The following is a description of a gene set: studied in species Mus musculus from publication Cui A, Huang T, Li S, Ma A, Pérez JL, Sander C, Keskin DB, Wu CJ, Fraenkel E, Hacohen N (PMID 38057668) Mouse Gene Set: CUI_T_CELL_GD_RANKL_RESPONSE_UP Genes positively differentially expressed in cell type: γδ T cell upon treatment with cytokine: RANKL in mouse lymph nodes in vivo. Cytokines mediate cell-cell communication in the immune system and represent important therapeutic targets. A myriad of studies have highlighted their central role in immune function, yet we lack a global view of the cellular responses of each immune cell type to each cytokine. To address this gap, the authors created the Immune Dictionary, a compendium of single-cell transcriptomic profiles of more than 17 immune cell types in response to each of 86 cytokines (>1,400 cytokine-cell type combinations) in mouse lymph nodes in vivo. A cytokine-centric view of the dictionary revealed that most cytokines induce highly cell-type-specific responses. For example, the inflammatory cytokine interleukin-1β induces distinct gene programmes in almost every cell type. A cell-type-centric view of the dictionary identified more than 66 cytokine-driven cellular polarization states across immune cell types, including previously uncharacterized states such as an interleukin-18-induced polyfunctional natural killer cell state., and this is the list of marker genes: Stub1, Ly6e, Trac, Srsf9, Ly6a, Psen2, Tubb4b, Ly6g5b